The following is a description of a gene set: Our data indicated that activation of the PPARg nuclear receptor induces a retinoid response in human dendritic cells. In order to assess the contribution of retinoid signaling to the PPARg response we decided to use a combination of pharmacological activators and inhibitors of these pathways. Cells were treated with the synthetic PPARg ligand rosiglitazone (RSG), or with RSG along with the RARa antagonist (AGN193109) to block RARa mediated gene expression, or the RARa specific agonists (AM580) alone. This design allows one to determine if retinoid signaling is a downstream event of PPARg activation and what portion of PPARg regulated genes are regulated via induced retinoid signaling. Human Gene Set: GSE5679_CTRL_VS_PPARG_LIGAND_ROSIGLITAZONE_TREATED_DC_DN species: Homo sapiens from publication Szatmari I, Pap A, Rühl R, Ma JX, Illarionov PA, Besra GS, Rajnavolgyi E, Dezso B, Nagy L (PMID 16982809) Genes down-regulated in monocyte-derived dendritic cells: untreated versus rosiglitazone., and this is the list of marker genes: ZNF274, LATS2, CFAP141, CLCN4, PIGL, CAPN15, SLC17A5, MATK, TMEM191C, CCNL2, USP11, GCLC, RYR3, PEAR1, RHEBL1, PLCB4, MSRB3, OSBPL9, CXCR4, CLCN2, PTPN13, XDH, RORA (NCBI Gene Id 6095), TUBB2A, CISD2, ITGB8, RNF146, OTUD4, CHDH, CD151, DERL1, TRIM2, DGAT1, AKTIP, SLC20A1, HABP4, FRMD6, ETS1, STK24, GLUL, NEIL1, PRKCA, WDR91, TIAM1, HNRNPK, OTULINL, STAT5B (signal transducer and activator of transcription 5B), HERPUD2, IP6K1, ZNF862, ATP6V0D2, RASA2, HACE1, CYB561D1, FCSK, FPGT, ROCK1, L1CAM, INPP4B, MARVELD1, ATRX, RAI1, EIF4G3, CCDC62, MIB2, RGS2, TMEM181, PANK1 (NCBI Gene Id 53354), KIAA0232, PYROXD1, PREB, RFX3, PNRC1, OAZ2, CATSPERD, RNASE4, HLA-B, ELAC1, ARIH2, INPP5F, TRIP6, KLF9 (KLF transcription factor 9), NIBAN1, LTBP3, PRKAG2, LCLAT1, IKZF4, MTMR11, DDX5, NR3C2, TERT, TNFAIP3, ZC3H7A, FHIP2B, MCOLN1, DNAJA4, BACH1, STX16, ITGB5, NBEAL2, TNRC6B, H2AC18, CACNA2D2, ZNF571, VPS54, RASGEF1A, STX1A, FBXW11, CARNS1, IFFO2 (NCBI Gene Id 126917, intermediate filament family orphan 2), PIP4K2B, TMT1A, ANKRD6, REXO5, DCUN1D4, ZBTB2, PTTG1, LEPROT, SH3BGRL, FLCN, AKAP8, SLC35D1, ARHGEF12, AGRN, ATG4C, SCAF8, DUSP1, AKAP8L, RIIAD1, C3orf70, B4GALNT4, MSS51, PRR14, UPF3B, C3orf80, AHNAK, MCMBP, LDLRAD4, ARID4A, PNCK, BSDC1, PHLPP1, ZFP36L1, CRKL, SH2B1, MPRIP, PINK1, PRPF39, HDAC9, TCTA, ADGRE5, PLCL1, TPP2, PLAGL1, CPEB2 (cytoplasmic polyadenylation element binding protein 2), MIR22HG, VSIG10, TCN2, NISCH, SNX13, SH3BGRL2, TMEM35B, CREBZF, CDKN1B (cyclin dependent kinase inhibitor 1B), RABGAP1L, GTF2IRD1 (NCBI Gene Id 9569), NTN4, PAXBP1, ZC3HAV1, ITM2B, MAN2A2, PTGER2, S100A4, TRMT13, SUCO, PIK3R1, MICU3, ACSBG1, ARHGAP5, WASL, YPEL2, GGNBP2, CAMK2N1, PDE4DIP, APBB1, MNT, PATL2, ZC3H7B, TRIM11, FAAH, PCYT1B, KRAS, MATN2, GPR155, SLC43A2, CHMP5, ANKRD16, UBP1, KLF6, FAM193B